The following is a description of a gene set: Mouse Gene Set: TABULA_MURIS_SENIS_KIDNEY_MACROPHAGE_AGEING studied in species Mus musculus from publication Tabula Muris Consortium (PMID 32669714), and this is the list of marker genes: Slc25a5, Pgk1, Il2rg, Fgr, Ms4a6d, Smpdl3a, Sec61b, Txn1, Ahnak, Sod2, Cebpb, Vim, Ly6a, Clec12a, Cd44, Agpat4, Ier3, Prdx2, Rida, Tmsb10, Gpx3, Junb, Itga4, Fis1, Napsa, Cd84, Alox5ap, Cox5a, Msrb1, H2aj, Cmip, Gngt2, Ctsd, Acp5, Capg, Lmo4, Gdf3, Pltp, Adgre5, S100a4, Sirpb1c, Ndufa1, Pla2g7 (NCBI Gene Id 98095), Uqcrq, Smdt1, Fos, Atp5pd, Vamp8, Cd300a, Gsr, Clec4a1, Rbm3, Rpl31-ps12, Ccl2, Sec61g, Btg1, Ywhaz, AB124611, Zfp36, Klf4, Ccl6, Reep5, Atp5mj (ATP synthase membrane subunit j), Samsn1 (NCBI Gene Id 67742), Miox, Spink1, Hint1, Idh1, Lrp1, Prr13, Cd47, Lyz2 (NCBI Gene Id 17107), Dbi, Sp140, Lgals3, Atp5mg, Emp3, Jund, Cfp, H3f3a, Ms4a7, Ms4a6c, Rpl10, Gpx4, Ccl5, Trem2, Nadk, Ninj1, Ccl9, S100a6, Rap2b, Prdx5, Aldh2, Ifitm2, Lyz1, Cstb, Sat1, Tmem160, Atp1b3, Plac8, Zeb2, Gmfg, Grn, Ifi30, Itgam, Cyba, Socs3 (NCBI Gene Id 12702), Mcl1, Scand1, Ly6e, Klf2, Tnfaip2, Ptpn1, Ezr, Rpl36al, Rpl28, AW112010